The following is a description of a gene set: species: Mus musculus part of: Downstream signaling of activated FGFR4 This event has been computationally inferred from an event that has been demonstrated in another species.<p>The inference is based on the homology mapping from PANTHER. Briefly, reactions for which all involved PhysicalEntities (in input, output and catalyst) have a mapped orthologue/paralogue (for complexes at least 75% of components must have a mapping) are inferred to the other species. electronically inferred by orthology from the curated human pathway Reactome Pathway: SHC-mediated cascade:FGFR4, and this is the list of marker genes: Fgf8, Fgf1, Fgf6, Fgf17, Fgf20, Shc1, Hras, Fgf23, Klb, Fgf16, Grb2, Fgf2, Fgf4, Fgf15